The following is a description of a gene set: species: Mus musculus The series of molecular signals initiated by binding of a ligand to a member of the ERBB family of receptor tyrosine kinases on the surface of a cell, and ending with the regulation of a downstream cellular process, e.g. transcription. Mouse Gene Set: GOBP_ERBB_SIGNALING_PATHWAY, and this is the list of marker genes: Epgn, Map2k1, Errfi1, Psen1, Lgmn, Fam83b, Epha7, Flt4, Tyro3, Spry2, Fgfr2, Insrr, Tsg101, Snx5, Wdr54, Ptprf, Shc1, Vps25, Bcar1, Erbb3, Plcg1, Ephb4, Egf, Ceacam1, Musk, Slc30a10, Psen2, Rnf115, Zgpat, Pde6g, Ceacam2, Agr2, Hap1, Map2k2, Alk, Epha8, Cadm1, Gper1, Rtn4, Dab2ip, Abl2, Cblb, Ptprj, Dgkd, Plaur, Rhbdf2, Met, Esr1, Tgfa, Sos1, Vil1, Neu3, Ephb2, Tfap2a, Agt, Ddr2, Hip1, Epha10, Ntrk1, Braf, Hras, Grb2, Ltk, Cdh13, Epha4, Ntrk3, Fam83a, Myoc, Mertk, Fgfr1, Cripto, Iqgap1, Pde6h, Epha6, Rab7, Fgfr4, Prickle1, Socs5, Rala, Mvp, Shkbp1, Ptk2b, Epha2, Efemp1, Rassf2, Gprc5a, Flt1, Ephb1, Nrg4, Ror2, Egfr, Kit, Nrg1, Mmp9, Npr2, Epha1, Csf1r, Chmp6, Rbpj, Ccdc88a, Gab1, Adgre4, Afap1l2, Kdr, Btc, Mapk1, Cpne3, Epha5, Axl, Mst1r, Abl1, Tgfb1, Mvb12a, Insr, Caml, Fgfr3, Fasl, Pigr, Adam17, Raf1, Kif16b, Src, Tek, Nrg3, Bace1, Zfyve28, Rhbdf1, Rnf126, Fer, Hip1r, Cbl, Mep1a, Garem1, Spg21, Ptpn11, Sh3tc2, Socs4, Ddr1, Mapk3, Adra2a, Pdpk1, Ptpn2, Tie1, Ereg, Klk8, Mvb12b, Ptprr, Akt1, Areg, Pdgfra, Ret, Arf4, Igf1r, Hbegf, Sox9, Ros1, Esr2, Ptpn12, Cnot9, Erbb4, Plce1, Ephb3, Acp4, Dusp3, Dbx2, Erbb2, Nrg2, Ptk2, Cblc, Ntrk2 (neurotrophic tyrosine kinase, receptor, type 2), Adam10, Flt3, Nppa, Nup62, Ralb, Itga1, Bcar3, Epha3, Pdgfrb